Given this list of marker genes Or6d12, Syngr1, Dennd2d, Pax9, Tcf7l2, Arl6ip5, Kcnj15, Pot1b, Nktr, Chac1, Sh3bp2 (SH3-domain binding protein 2), Cntln, Zfta, Camk2g, Mef2c, Rdh13, Col11a2, Polr1d, Med17, Dock2, Zfp280d, Zfp945, Ampd2, here is a description of the gene set: Genes predicted to be targets of miRBase v22 microRNA mmu_miR_3091_5p in miRDB v6.0 with MirTarget v4 prediction scores > 80 (high confidence targets). Mouse Gene Set: MIR_3091_5P from publication Chen Y, Wang X (PMID 31504780) studied in species Mus musculus